Given this list of marker genes Pde2a, Oprm1, Lpar1, Pde10a, Pde3a, Pde3b, Cdc34 (NCBI Gene Id 216150), Pde11a, Nucb2, Ube2b, Cdc34b, Npy2r, Mgrn1, Oprl1, Aplnr, here is a description of the gene set: studied in species Mus musculus Mouse Gene Set: GOBP_NEGATIVE_REGULATION_OF_CAMP_MEDIATED_SIGNALING Any process which stops, prevents, or reduces the frequency, rate or extent of cAMP-mediated signaling.